Given this list of marker genes ATE1, TMEM86A, P2RY14, TUT4, CNOT6, PRR3, HIPK1, RIC8B, SLAIN2, FBXL14, CCDC117, TIPRL, POU6F1, MTCP1, MAT2B, TMEM120A, COMMD3, VRK1, ATRAID, MTA1, SPTBN1, ITGB2, UBE3B (ubiquitin protein ligase E3B), POLB, HVCN1, DGCR8, TMEM9B, RAB18, ALDH1B1, TBC1D8B, SLC49A4, ASB3, SEMA4D, ANTXR2, EHD4, GBE1, RAD52, SLC12A9, GCOM1, MTA3, SLC44A2, IKZF1, NECAP2, PNPLA2, RASA3, HERC6, MAP4K3, MTMR1, CARD11, ADGRE5, ALDH7A1, PKIG, WDR7, SMYD3, ARHGEF6, MAPK9, DHRS1, SASH3, TMEM192, PLEKHB2, MATN2, ERP29, SLC9A9, CDK19, SH3TC1, CDKN2D, SMC6, CDH1, PHF14, DYM, FBH1, GPR155, UBR2, TAF6L, EXOC6, HARS2, LSP1, PON2, TRAPPC2B, GRAMD1C, RTF1 (RTF1 homolog, Paf1/RNA polymerase II complex component), C19orf12, PHLPP2, NUDT3, ZFYVE19, C1orf174, STAMBPL1, RAB33B, PEPD, PLOD2, MARK3, NAGA, C5orf34, DAP, PANX1, AARSD1, EXOC4, RXYLT1 (ribitol xylosyltransferase 1), PRKRA, CERS6, COP1, MEF2A, CALHM2, WBP1, PIH1D1, ARHGEF10, PRRC2B, STAU2, TPD52, DDB1, TTC33, TNFSF10, EVL, ELF1, ILVBL, RBL1, NCDN, PDLIM1, INPP5D, TMEM179B, AAK1, HPSE, SDC3, AMDHD2, ECH1, ZMYM2, UBL3, ETNK1, TANGO2, BCKDHA, LIMD1, BNIP2, RNASEL, PLS3, RASAL3, ARID1B, DCUN1D2, FKBP15, PTP4A3, RHOT1, GNG12, KCTD2, MCUR1, ITPRID2, RGS2, CASP2, CXCL9, RASA4, NGLY1, RASL11B, RFC1, CHD9, MRTFA, FERRY3, SYNRG, DUBR, ABCB1, WFS1, C16orf54, SMIM5 (small integral membrane protein 5), GNGT2, MYO1C, CEP192, C11orf54, SMS, HLTF, NEIL1, GNPTAB, STOML1, SRD5A3, ISG20, PLGRKT, HPS3, UPB1, MYO18A, SMAP2, ACBD5, PRP4K, PINK1, SGPP1, CDADC1, CYP27A1, TRIM25, KLC4, MYH10, GNE, ARHGEF11, CRYBG1, WDPCP, LIFR, IFNGR1, EIF2B4, GPR35, SLC35F5, PRKD3, PAQR5, TUBGCP5, ITSN2, P2RY12, KBTBD11, here is a description of the gene set: Human Gene Set: GSE46606_DAY1_VS_DAY3_CD40L_IL2_IL5_STIMULATED_IRF4MID_BCELL_DN species: Homo sapiens Temporal analysis of B cell activation in vitro using CD40L and IL-2/4/5 cytokines in wild type Irf4+/+ B cells or in mutant Irf4-/- B cells harboring a tet-inducible allele of Irf4. IRF4 expression was restored, or not, in the Irf4-/- background by culturing in the presence of low or high concentrations of doxycycline. The results provide insight in the role of IRF4 expression levels in coordinating different programs of B cell differentiation. from publication Ochiai K, Maienschein-Cline M, Simonetti G, Chen J, Rosenthal R, Brink R, Chong AS, Klein U, Dinner AR, Singh H, Sciammas R (PMID 23684984) Genes down-regulated in CD40L and IL-2 IL-4 IL-5 stimulated at day 1 B cell IRF4intermediate versus CD40L and IL-2 IL-4 IL-5 stimulated at day 3 B cell IRF4intermediate.